The following is a description of a gene set: Human Gene Set: DESCARTES_MAIN_FETAL_LYMPHATIC_ENDOTHELIAL_CELLS from publication Cao J, O'Day DR, Pliner HA, Kingsley PD, Deng M, Daza RM, Zager MA, Aldinger KA, Blecher-Gonen R, Zhang F, Spielmann M, Palis J, Doherty D, Steemers FJ, Glass IA, Trapnell C, Shendure J (PMID 33184181) The gene expression program underlying the specification of human cell types is of fundamental interest. The study authors generated human cell atlases of gene expression and chromatin accessibility in fetal tissues. For gene expression, the study authors applied three-level combinatorial indexing to >110 samples representing 15 organs, ultimately profiling ~4 million single cells. The study authors leveraged the literature and other atlases to identify and annotate hundreds of cell types and subtypes, both within and across tissues. Our analyses focused on organ-specific specializations of broadly distributed cell types (such as blood, endothelial, and epithelial), sites of fetal erythropoiesis (which notably included the adrenal gland), and integration with mouse developmental atlases (such as conserved specification of blood cells). These data represent a rich resource for the exploration of in vivo human gene expression in diverse tissues and cell types. species: Homo sapiens Marker genes curated from the annotated cluster as represented in the Descartes Human Gene Expression During Development database., and this is the list of marker genes: EFCC1, SELENON, MAP3K1, SPHK1, RNU7-13P, ANKDD1A, TCTN3, PTX3, GIMAP5, PLSCR4, ZNF24TR, RAB11FIP5, INO80C, PGM5 (phosphoglucomutase 5), UBTD1, ADD3-AS1, CYP2AC1P, DTX1, CNTNAP3B, ZP2, NFATC1, ENSG00000233358, KBTBD11, TSPEAR, SLC27A3, LYVE1, LINC00636, DIPK2B, GFUS, CYP46A1, WFS1, SLC35E4, GPR182, GJA1, GNG12-AS1, TBX1, TNFRSF11A, TMEM255B, GJD3, ZNF341-AS1, LRRC70, ENSG00000212594, STAB2, NRP2, ENSG00000233178, TNFAIP8L3, LINC02147, PRR5L, HOMER3, FCGR2C, KLHL3, NTS, ARL4A, PARD6G, S100A16, ADGRG3, GRAP, CASP12, PGM5-AS1, SHC1, GJC2 (gap junction protein gamma 2), PLEKHO2, GRAPL, GNG11, TFPI, PDE2A, PIEZO1, RAB3IL1, LINC02005, EFNA5, RADIL, C2CD4D, PPFIBP1, RHOJ, LOX, KLHL4, ENSG00000269155, SMAD1, TMEM140, RASSF9, MSMP, SMAD1-AS1 (SMAD1 antisense RNA 1), LINC02058, FLT4, MAP4K2, TIE1, ELK3, IRAG1-AS1